The following is a description of a gene set: part of: Metabolism of RNA studied in species Mus musculus electronically inferred by orthology from the curated human pathway Reactome Pathway: mRNA Capping This event has been computationally inferred from an event that has been demonstrated in another species.<p>The inference is based on the homology mapping from PANTHER. Briefly, reactions for which all involved PhysicalEntities (in input, output and catalyst) have a mapped orthologue/paralogue (for complexes at least 75% of components must have a mapping) are inferred to the other species., and this is the list of marker genes: Polr2k, Polr2e, Gtf2h4 (NCBI Gene Id 14885), Polr2i, Gtf2h2, Rngtt, Polr2l, Polr2f, Gtf2f2, Supt5, Ercc3, Polr2c (NCBI Gene Id 20021), Polr2a, Ccnh, Ercc2, Rnmt, Polr2b, Gtf2f1